The following is a description of a gene set: species: Mus musculus from publication Cui A, Huang T, Li S, Ma A, Pérez JL, Sander C, Keskin DB, Wu CJ, Fraenkel E, Hacohen N (PMID 38057668) Cytokines mediate cell-cell communication in the immune system and represent important therapeutic targets. A myriad of studies have highlighted their central role in immune function, yet we lack a global view of the cellular responses of each immune cell type to each cytokine. To address this gap, the authors created the Immune Dictionary, a compendium of single-cell transcriptomic profiles of more than 17 immune cell types in response to each of 86 cytokines (>1,400 cytokine-cell type combinations) in mouse lymph nodes in vivo. A cytokine-centric view of the dictionary revealed that most cytokines induce highly cell-type-specific responses. For example, the inflammatory cytokine interleukin-1β induces distinct gene programmes in almost every cell type. A cell-type-centric view of the dictionary identified more than 66 cytokine-driven cellular polarization states across immune cell types, including previously uncharacterized states such as an interleukin-18-induced polyfunctional natural killer cell state. Genes negatively differentially expressed in cell type: Langerhans upon treatment with cytokine: IL-1β in mouse lymph nodes in vivo. Mouse Gene Set: CUI_LANGERHANS_IL1B_RESPONSE_DN, and this is the list of marker genes: Hspa1b, Spi1, Slc6a6, Sqstm1, Gbp8, Thap2, Nav1, Ncf2, Icam1, Mx1 (MX dynamin-like GTPase 1), Laptm5, Specc1, Slc38a2, Slc29a3, H2-Q6, Tnfrsf1b, Cd52 (NCBI Gene Id 23833), Ctsh, Vrk2, Phf21a, Rassf4, Rapgef5, Tubb5, Haus8, Zmynd15, Tcf7l2, Celf2, Ankrd35, Ucp2, Brk1, H2-M2, Ttll5, Ostf1, Man1a, Trim7, Ank, Stard7, Relb, Castor2, Rasa4, Adam8, Icosl, Micu1, Anxa3, Mxd1, Kynu, Eno3, H3f3a, Tmem150c, Aif1, H2bc4, Creg1, Tmem176a, Zfp36l1, Fam32a, Nrbf2, Rcsd1, Pgap2, Asap1 (ArfGAP with SH3 domain, ankyrin repeat and PH domain1), Evi2a, Capn7, Sh3bp1, Cacnb3, Abcg1, Atf7ip, Arl5a, Ighm, Glipr1, Sbno2, Extl1, Lyst, Fbrsl1, Tmem176b, Sat1, Etv3, Galnt12, Ypel3, Eif4a2, Chka, Snrnp25, Adam23 (NCBI Gene Id 98648), H2az1, Trio, Hmgb1, Arl5c, Ftl1, Uvrag, Rgs3, Entrep1, S100a4, Epb41l2, Hebp1, Apol7c, Gnl2, Cd207, Mylip, Pik3r3, Swap70, Adm, Arpp19, Cyba (cytochrome b-245, alpha polypeptide), Rab32, Vcam1